Given this list of marker genes KRI1, NOP14 (NOP14 nucleolar protein), ABT1, RCL1, BOP1, EXOSC2, RRS1, EXOSC3, NOP9, RPS21, EXOSC9, EXOSC10, FCF1, ERI1, URB1, NOL9, PES1, WDR12, FTSJ3, EXOSC8, UTP20, RPP40, EXOSC7, here is a description of the gene set: studied in species Homo sapiens Any process involved in the maturation of an rRNA molecule originally produced as part of a tricistronic rRNA transcript that contained the Small SubUnit (SSU) rRNA, the 5.8S rRNA, and the Large SubUnit (LSU) rRNA, in that order, from 5' to 3' along the primary transcript. Human Gene Set: GOBP_MATURATION_OF_5_8S_RRNA_FROM_TRICISTRONIC_RRNA_TRANSCRIPT_SSU_RRNA_5_8S_RRNA_LSU_RRNA